Given this list of marker genes EFEMP2, ALDH18A1, FBLN5 (NCBI Gene Id 11268), ELN, LTBP1, here is a description of the gene set: species: Homo sapiens Small bowel diverticula Human Gene Set: HP_SMALL_BOWEL_DIVERTICULA